The following is a description of a gene set: Human Gene Set: REACTOME_PENTOSE_PHOSPHATE_PATHWAY Pentose phosphate pathway studied in species Homo sapiens, and this is the list of marker genes: PRPS1L1, RPIA, DERA, PRPS2, TKT, PRPS1, PGLS, PGD, RBKS, PGM2, SHPK, TALDO1, RPEL1, G6PD, RPE